The following is a description of a gene set: species: Homo sapiens Any process that modulates the frequency, rate or extent of the Tl signaling pathway. Human Gene Set: GOBP_REGULATION_OF_TOLL_SIGNALING_PATHWAY, and this is the list of marker genes: PELI1, APP, PELI2, SIGIRR, PELI3, NLRP12